Given this list of marker genes HEATR3, TINF2, PIEZO1, HBB, RPS19, RPL11, TERC, EFL1, RPS28, TERT, RPL31, ADA2, ETV6, LIG1, SAMD9L, RPS29, MTRR, RPS20, RPS7, RPS15A, RPL27, RPS17, POT1, RPL26, RPL8, DNAJC21, ABCB6, ANKRD11, LARS2, RPS24, SLC4A1, RPL5, DUT, CBLIF, TSR2, RPL15 (ribosomal protein L15), RPL18, RPS10, RPL35, RPS26, RPL9, RHAG, MDM4, KIF23, RPL35A, RACGAP1, SAMD9, RPS27, DHFR, GATA1, KCNN4, SBDS (SBDS ribosome maturation factor), MMADHC, here is a description of the gene set: species: Homo sapiens Human Gene Set: HP_INCREASED_MEAN_CORPUSCULAR_VOLUME Increased mean corpuscular volume Larger than normal size of erythrocytes.